The following is a description of a gene set: Any process that activates or increases the frequency, rate or extent of type 2 mitophagy. studied in species Homo sapiens Human Gene Set: GOBP_POSITIVE_REGULATION_OF_TYPE_2_MITOPHAGY, and this is the list of marker genes: ATP5IF1, MUL1, GBA1, HDAC6, VDAC1, CDC37, TOMM7, HK2, PINK1, HUWE1, PRKN (NCBI Gene Id 8004)